The following is a description of a gene set: Genes predicted to be targets of miRBase v22 microRNA hsa-miR-33a-3p in miRDB v6.0 with MirTarget v4 prediction scores > 80 (high confidence targets). Human Gene Set: MIR33A_3P from publication Chen Y, Wang X (PMID 31504780) studied in species Homo sapiens, and this is the list of marker genes: GRIA2, FGD4, TOGARAM1, PHACTR2, TEFM, REEP3, PAK5, CD8A (NCBI Gene Id 925), SKIC3, GIPC2 (GIPC PDZ domain containing family member 2), AGMAT, NDN, PLPP3, HPF1, SLC1A3, MFSD14A, ZNF558, FCHO2, EPM2AIP1, HSPA13, LGSN, CUL5, USP19, GNA13, TRIM2, PARP8, ALDH1L2, ZMYND11, PCLAF, CP, KMT5B, PFKP, GJA1, HNRNPU, EPCAM, AKAP9, SLC4A4, SLBP, PARP15, GULP1, ZNF704, ARHGAP5, PABPC1, CRISPLD1, THSD7A, EPHA5, HAND1, N4BP2, CADM2, BCL6, HEXIM1, ANGPTL3, NIT1, SFMBT1, TM9SF3, CPLANE1, YIPF4, ZNF148, API5, ULK4, VSX1, FOXN2, SLC18B1, CCDC88A, SDK1, SLC17A2, CSNK1A1, GLIS1, PCDHA9, SHE, TMF1, PCGF6, KPNA1, SMIM14, SZRD1, NECTIN3, SUB1, NAA25, ITGB1BP1, GABRA4, CREB1, ZNF367, YAF2, ANKIB1, CYRIA, THOC1, SAMD8, KCNQ5, CENPC, SF3B1, LINC03040, CXCL5, HUS1, EBAG9, CYP24A1 (NCBI Gene Id 1591), GUCD1, TMA16, CREBRF, ARHGEF38, DLAT, RTKN2, SCAI, ZNF749, TBRG1, RESF1, DCUN1D1, MAMLD1, AFF1, CLDND1, EIF3A, PRRG1, HYDIN, METTL3, AKAP5, CNOT7, LIMS1, DENND5A, TFAP2A, ZMAT4, ST6GALNAC3, LARP4, CLDN12, RALGPS2, ACADL, SPIN1, DNTTIP2, PPHLN1, ERH, FRS2, LSM14A, CNTN4, AQP4, RNF170, PEA15 (proliferation and apoptosis adaptor protein 15), CCNL1, UBE2N, DMRTA1, NPAS3, SETBP1, ZNF292, DIP2C, WDR26, CLK4, BRWD3, NFATC3, ROR1, CD48, AP3S1, EFCAB2, PRDX3, STIM2, MAML3, PDE10A (phosphodiesterase 10A), DPP8, WDR82, SNX10, RBM46, LUM, MPEG1, GOPC, VWA5A, LIN54, ATE1, SMC6, CCND2, KCNMA1, SLC5A1, RPP30, PCSK2, MRC1, RTTN, HDAC9, EHMT1, RPL14, C5orf63, ELAVL1, RASAL2, HOXA4, ZNF680, GIT2, HNRNPR, RFX3 (regulatory factor X3), IFI16, CMPK2, EVA1A, MIB1, PLPBP, RUNDC3B, C7orf57, PASD1, HTR1E, CDC42SE2, GPD1L, IPMK (NCBI Gene Id 253430), ZNF781, MCCC2, CDK15, PRSS50, GRB10, NR3C1, SEPTIN6, LGALS8, GPR85, TMEM132B, MTF2, UBN2, FBXO30, RIF1, WAPL, LRRC3B, ZNF277, MAN2A1, SLC38A1, LEMD3, FIGN, FRG2C, AGAP1, HOOK1, DPF2, CLEC12A, ZNF420, UBQLN1, RASSF6, PAH, SRI, RBCK1, C5orf15, ZNF607, TMTC2, CCSER2, ALG10B, ZNF800, PPM1D, HEY2, PELI1, ANXA5, PLA2G4A, TSHZ3, ALG6, PURA, DCLK1, RRP15, S1PR1, CANX, NAE1, BLM, MRGPRF, NUGGC, MED21, SMIM21, TBX18, FBXO36, MEX3C, NFKBIZ, STRN, GJB2, LIMA1, HRH4, SPAG1, MYO1B, PHTF2, CPEB2, KRAS (KRAS proto-oncogene, GTPase), PDIA6, SRSF1, HOOK3, TNRC6B, STRIP2 (NCBI Gene Id 57464), ZNF92, ZNF43, KBTBD8, BSN, CPD, FMR1, RMI1, NUS1, WIF1, PCDH17, CD1C, NECAP1 (NECAP endocytosis associated 1), SEC63, RAB38, RARB, RFX7, UQCC1, NRP2, LARP7, TMEM196, ZNF678, TOP2B, DNAJC21, ENKD1, FABP5, NIPA1, TMEM237, YTHDC1, ZSCAN32, JMJD1C (NCBI Gene Id 9323), NUFIP2, OSTF1, ZNF280C, KLF12, EFCAB11, COL4A3, HECTD1, AFF2 (ALF transcription elongation factor 2), IP6K2, DPY19L4, ABCA10, HLCS, WASHC4, LRRC42, NCEH1, CLEC5A, HSPA2, ZZZ3, CACNA2D1, TNFRSF21, USP38, ETV1, ISL1, ARAP2, LCA5, CAMK1D, MARCHF1, BCOR, REV3L, CFLAR, ELF1, SFRP2, ELL2, CENPK, ATP8A1, CAV2, FAM91A1, SPRING1, UBE2D3 (ubiquitin conjugating enzyme E2 D3), KLF3, SLC2A12, AGGF1 (NCBI Gene Id 55109), CCDC112, ARFGEF1, CEP170, KCND2, LYN, UBE2J1, HAPLN3, CD2AP, PRKCH, ZNF580, ATXN3, MAP1LC3B, GLDN, NBPF15, MET, DLL4, LRCH2, MMD, AFAP1L2 (actin filament associated protein 1 like 2), C1QTNF1, TEX101, COL9A1, FLG2, DEPDC1, SLC16A7, SLC2A11, CTTN, TENM1, CPT1A, SLC7A11, GUCY1A2, TMEM184C, GPM6B, ZNF146, SASH1, CITED2, HAL (NCBI Gene Id 3034), SLC26A7, KMT2E, CACNB4, CCDC71L, ASCL4, USP15 (NCBI Gene Id 9958), ZNF254, KIF26B, BCL2, TMEM101, LMO7, PTAR1, PPP3CA, IGF1, RNF34 (NCBI Gene Id 96268), SPAG9, SMIM13, RNF6, TMEM50A, SLC25A16, NEBL, PAXBP1, LOX, LPP, UNC80, RORA, CLOCK, NEK9, C3AR1, CUBN, VAMP7, DIXDC1, HYCC2, HACD3, GAB1, NAPEPLD, ELOVL4, CFL2, UBQLN2, PSIP1, NXPH2, INTS6 (NCBI Gene Id 26512), PRF1, ZFAND5, ZFP69, SH2D1B, TMEM220, DHX15, CCDC89, PHYHIPL, NOD2, TNFAIP6, FAT1, MS4A1